The following is a description of a gene set: studied in species Mus musculus TRAF6 mediated NF-kB activation Mouse Gene Set: REACTOME_TRAF6_MEDIATED_NF_KB_ACTIVATION, and this is the list of marker genes: S100b, Chuk, Rela, Nfkbia, Nfkb2, Nfkbib, Nkiras1, Nfkb1, App, Hmgb1, Ikbkb, Nkiras2, Ikbkg, Ager